The following is a description of a gene set: Any process that stops, prevents, or reduces the frequency, rate or extent of the chemical reactions and pathways involving carbohydrate. Human Gene Set: GOBP_NEGATIVE_REGULATION_OF_CARBOHYDRATE_METABOLIC_PROCESS studied in species Homo sapiens, and this is the list of marker genes: SMPD3, HDAC4, ADIPOQ, TCF7L2, PPP1R3B, PRKN, INPP5K, PRKACA, NR0B1, PGP, TIGAR, MIR195, MIDN, MIR1271, ACTN3, NUPR1, SIRT6 (sirtuin 6), SELENOS, DDIT4, SLC4A1, MIR15B, LEPR, STAT3, TRIM63, PRKG1, PASK (NCBI Gene Id 26144), AP2A1, GRB10, SIK1, INS, CBFA2T3, GCK, IER3, PPARA, TP53, PLEK, C1QTNF3, MST1, CLK2, GSK3B, GCKR, MTCH2, FBP1, PFKFB1, PPP2CA, SERPINA12, CLTC, KAT2A, GIT1 (NCBI Gene Id 28964), ENPP1, NCOR1, USP7, C1QTNF12, CRY1, EP300, GSK3A, TGFB1, PRKAG3, MTCL2, FLCN, ERFE